The following is a description of a gene set: studied in species Homo sapiens Catalysis of the reaction: L-lysyl4- + 3 S-adenosyl-L-methionine = 2 H+ + N6,N6-trimethyl-L-lysyl4- + 3 S-adenosyl-L-homocysteine. This reaction is the successive addition of three methyl groups to the unmethylated lysine residue at position 4 of histone H3, producing histone H3K4me3. Human Gene Set: GOMF_HISTONE_H3K4_TRIMETHYLTRANSFERASE_ACTIVITY, and this is the list of marker genes: SETD1A, SETD1B (NCBI Gene Id 23067), SMYD1, PRDM9 (PR/SET domain 9), SMYD2, KMT2C, KMT2A, KMT2B, KMT2D, SMYD3